The following is a description of a gene set: Difficulty distinguishing between yellow and blue, possible related to dysfunction of the S photopigment. Human Gene Set: HP_TRITANOMALY studied in species Homo sapiens Tritanomaly, and this is the list of marker genes: OPA1, GUCY2D, OPA3, C1QTNF5, RBP4, OPN1SW, NR2E3, DNM1L, POC1B